Given this list of marker genes EGFR, CASP3, DNAJB5, NDP, GPR15LG, CXCL8, BCL11A, ITGA9, DCST2, FAAP20, TMPRSS6, GIPR, ICOSLG, FSCN1, RUFY2, CASQ2, CCL15, MAP2K3, VCX, AFF3, BROX, CSF3 (colony stimulating factor 3), MORN1, NAMPT, MARCKS, MCF2L, ENPEP, RELA, KCNAB1, CSF1, AKAP5, MAGEA5P (NCBI Gene Id 9174), SEPTIN7, COMMD4, MYRFL, BPIFA3 (BPI fold containing family A member 3), EDN1, FERMT2, SLC38A3, PURB, TBC1D9, ATP2B1, CD44, PRR15, KIR2DL1, GARIN3, IL23A, ITGB8, USF3, DDR2, EPC1, HAS2, MPP3, KDM6B, COL28A1, TAFA5, TMEM217, GPR84 (NCBI Gene Id 57098), KLF12, ZCWPW1, SERPINE1, EMP2, ZNF778-DT, FZD7, ANGPTL4, FCAR, STBD1, CIMAP1B, S1PR3, SSX4, TMEM26, IRF8, PXDN, CLDN1 (claudin 1), TRPC5, DRC3, UTS2, CCRL2, TTC23, TYRO3, KRT6A, NAV2, KANK1, GAL3ST4, TGFB2, CD1B (NCBI Gene Id 910), REL, OGFRP1, FGF17 (NCBI Gene Id 8822), ZDHHC21, PDGFB, PRR23E, IL1R1, PLD1, SEMA6C, OTUB2, AP3B2 (adaptor related protein complex 3 subunit beta 2), LSS, ADAM17, RNF144B, GULP1, TLL2, CATSPERG, TUSC8, HOXB-AS3, C11orf96 (chromosome 11 open reading frame 96), PKP1, LINC01138, TLR2, VEGFA, PLPP3, ZEB2, SERPINB2, DAZ1, CCL4, P2RY1, LDLR, SAMD10, ALX3, G0S2, CCNA1, IER3, DRP2, TRAF1, PLK3, NCK2, ACAT1, GABRD, KIF1B (kinesin family member 1B), KXD1, NINJ1, NLRP14, TDRP, CD55, ANKRD50, FPR2, KDM7A-DT, FUBP3, SLC2A6, GLYATL1, SOX21, HS3ST3B1, SLC28A2, PNLIPRP1, ABCB9, ARHGAP22-IT1, CCN5, KRT40, STMN4, C5orf47, NFKBIA, NFKBID, HIPK3, NBR2, TIMM50, DOK6, EMCN, HSPA1A, SGPP2, YRDC, AGBL5, CECR3, LIMS1, NHS (NHS actin remodeling regulator), RAB39A, CXCL3, EVI5L, COL3A1, ZNF277, CD82, CEMIP, ASIC1, CFAP251, PLCXD3, LINC02987, FSD1L, SRC, TNFSF9, PLK1, CHRDL2, DDX49, TSGA13, LINC00221, MIR22HG, CREB5, SPHK2, CA14, CXCL2, TAOK2, SEZ6, NFKB2, RORA-AS1, HECTD2, ICAM1, EFEMP1, DDX6, LINC00636, PNRC1, VAV2, RHOJ, KIF25-AS1, SGMS2, NOVA1, MIR3142HG, ARHGAP31, DYRK3, NPAS2, MRS2, SLC2A11, MAGEE2, SLC26A9, GAD2, CD24P4, SLC1A2, SEMA6A, NEMP1, TMLHE, SHD, MTF1, NRL, DYNC1I1, IRAK2 (interleukin 1 receptor associated kinase 2), USP12P1, FSCB, ATP2B2, ENSG00000282408, RDX, AKAP1, NKX3-1, COBL, CLEC4E, TMEM67 (NCBI Gene Id 91147), CDON, F2RL2, FOSL1, NBN (nibrin), CC2D2A, FUT4, RTKN2, MAPK11, DTX2, HAPLN1, CRISP3, GSK3B, FOXP2, RETN, MACROH2A2, BCL2L1, STAT5A (signal transducer and activator of transcription 5A), PTX3, KITLG, ZC3H12A, CAMP, HOPX, KLHL3 (NCBI Gene Id 26249), SOD3, MIIP, DSCAM, IMPG2, SLC6A15, TNN (NCBI Gene Id 63923), SPON1, LIPH, DENND5A, TACC3, BTBD9, PACRG, SRGAP1 (NCBI Gene Id 57522), ADCY1, RCN3, PNMA2, ADCY10, ERC1, EREG, GNG4, PIF1, SVEP1, OR51B5, GEMIN7, HTR7P1, TEAD2, IGFBP3, DGKG, TLR7, RPS2P45, CARD10, IGSF3, ZNF815P, BTG2, NOX4, IL18, NME7, CLCF1, AFF4, ABCC11, KMT2A (NCBI Gene Id 79951), NEFL, C4orf33, PIM3, PLEKHH3, PXDC1, CYP8B1, OR7C1, REM2, CYTH3, AGBL1, FHIP1A, HAL, IL12B, DCAF8, RAPH1, TPSAB1, NCAN, LINC02762, SPP2, KCNA2 (potassium voltage-gated channel subfamily A member 2), GLI4, P3H2, B4GALT5, NKAIN3, ELOVL7, GTSF1L, SNN, GPC3, PTPN21, CCL20, PNLIP, GAGE1, CA13, CFAP91, WNT5A (Wnt family member 5A), POU3F4, FGFR3, FFAR2, SPATA31G1, ADAM3A, HOXA6, C12orf50, TPD52, VWF, TP53INP2, TNFAIP3, LEKR1, NRG2, FNDC4 (fibronectin type III domain containing 4), MSC, NECAP2, HMGCLL1, AXDND1, LINC00269, CXCL10, TSLP, DOT1L, ESCO2, DNAH14, HNF4G, PDZRN3-AS1, EBF3, ENSG00000237870, SNAI1, TRIP10, HBA1, MFSD2A, COL5A1, KLHL41, SDC4, CD80, RPS6KA5, IL13RA2, NYX, NIPAL4, HPN, MRI1, GALNT13, RNF19B, CYP7A1, TGIF2LX, TAB1, C1QTNF7, NEB, TRIM36, PDE9A-AS1, CRYBA2, OTUD7B, BRICD5, PLAUR, PNPLA1, KLHL14, TMC6, JUN, NRAP, ACOD1, TP73, ARL4D, MDFIC, RAPGEF5, CRACR2A, ABL2 (NCBI Gene Id 27), ACSL1, LINC01270, HTRA3, RELB, IL1A, TNFRSF9, RIF1, IL1B, GOLIM4, MOB3C, TBX5, RASGEF1B, SYCE1, BMP10, LIMK2, SERPINB8, FGF9, RAB6B, GFER, FMN1, MIR124-1HG, KLF5 (KLF transcription factor 5), PPP1R15A, KREMEN1, GRIK2, ST7-AS1, POU5F1, JAG1, MAP3K19, C12orf54, PIKFYVE, WTAP, GEM, FGFR1OP2, CLINT1, CNTN4, CD83, WFDC9, ZC3H12C, LRP12, RASAL1, TP53AIP1, LEF1, RGS16, LINC00630, CXCL1, MS4A7, ENSG00000260779, RAG2, KLHL28, CFAP69, LINC00112, B4GALT1, TMOD4, SLC22A23, PRMT5-AS1, EOLA1-DT, TLNRD1, WNK4 (NCBI Gene Id 84361), ATP2B1-AS1, UBE2G2, PTGS2, UNC79, POSTN, PALM2AKAP2, HOXB1, KICS2 (NCBI Gene Id 144577), FZD4, UBE2FP1, TCTN1, EDA2R, SYT9, STXBP6, DDX42, BAMBI, CYP4A11, FGA, EHD1, TNFAIP2, SPEF2, UST-AS1, SEC14L4, SORBS2, CCL18, MEIOB, ABCD1P2, CTNNA2, LDHAL6A, HAGLROS, DPYSL3, ITGA8, NFKB1, ZNF131, CYP2C9, PAPPA, ANP32D, HSPA1B, DRAM1, IL6, KRT36 (keratin 36), TNF, DMRTA1, NEDD4L, PTPN1, ZNF286A, RAPGEF2, MYOG, LITAF, GREP1, SBSPON, CADPS, BRINP1, HPS4, ZNF876P, RAB3GAP2, MAFF, ZHX2 (NCBI Gene Id 22882), RIPK2, here is a description of the gene set: Genes up-regulated in macrophages by P.gingivalis FimA pathogen. Human Gene Set: ZHOU_INFLAMMATORY_RESPONSE_FIMA_UP Porphyromonas gingivalis (P. gingivalis) can trigger an inflammatory condition leading to the destruction of periodontal tissues. However P. gingivalis LPS and its fimbriae (FimA) play different roles compared with the live bacteria in the context of intracellular molecule induction and cytokine secretion. To elucidate whether this difference results from different signaling pathways in host immune response to P. gingivalis, its LPS, or its FimA, we examined gene expression profile of human macrophages exposed to P. gingivalis, its LPS, or its FimA. A comparison of gene expression resulted in the identification of three distinct groups of expressed genes. Furthermore, computer-assisted promoter analysis of a subset of each group of differentially regulated genes revealed four putative transcriptional regulation models that associate with transcription factors NFkappaB, IRF7, and KLF4. Using gene knockout mice and siRNA to silence mouse genes, we showed that both TLR2 and TLR7 are essential for the induction of NFkappaB-containing genes and NFkappaB-IFN-sensitive response element (ISRE) cocontaining genes by either P. gingivalis or its purified components. The gene induction via either TLR2 or TLR7 is dependent on both MyD88 and p38 MAPK. However, the unique induction of IFN-beta by P. gingivalis LPS requires TLR7 and IFNalphabetaR cosignaling, and the induction of ISRE-containing gene is dependent on the activation of IFN-beta autocrine loop. Taken together, these data demonstrate that P. gingivalis and its components induce NFkappaB-containing genes through either TLR2- or TLR7-MyD88-p38 MAPK pathway, while P. gingivalis LPS uniquely induces ISRE-containing genes, which requires IFNalphabetaR signaling involving IRF7, KLF4, and pY701 STAT1. species: Homo sapiens from publication Zhou Q, Amar S (PMID 18025224)